Given this list of marker genes PIP5K1A, PIP4K2A, PIP5K1C, PIPSL, PIP4K2C, PIP4K2B (NCBI Gene Id 8396), PIP5K1B, PIKFYVE, PIP5KL1, here is a description of the gene set: species: Homo sapiens Human Gene Set: GOMF_1_PHOSPHATIDYLINOSITOL_4_PHOSPHATE_5_KINASE_ACTIVITY Catalysis of the reaction: a 1-phosphatidyl-1D-myo-inositol 4-phosphate + ATP = a 1-phosphatidyl-1D-myo-inositol 4,5-bisphosphate + ADP + H+.